The following is a description of a gene set: Mouse Gene Set: DESCARTES_ORGANOGENESIS_CHONDROCYTES_AND_OSTEOBLASTS from publication Cao J, Spielmann M, Qiu X, Huang X, Ibrahim DM, Hill AJ, Zhang F, Mundlos S, Christiansen L, Steemers FJ, Trapnell C, Shendure J (PMID 30787437) species: Mus musculus Mouse Organogenesis Cell Atlas (MOCA) DE_gene_main_cluster.csv, fold.change>=1.5, qval<0.05, pval<0.05, and this is the list of marker genes: Gm31243, Col7a1, Nbl1, Wnt11, 2700069I18Rik, Cpxm2, Zfhx3, Tnfaip6, Twist2, Sema5a, Gm15997, Alx1, Glis1, Ednra, Mir6984, Tril, Xpnpep2, Runx2, Myorg, Lvrn, Gm5860, Notum, Dkk1, Zfhx4, Alx4, Srd5a2, a, Runx2os1, Gm15866, Dsc3, 4933431K23Rik, 5930403N24Rik, Car5b, Gm13652, Tbx2, Smc1b, Wdr27